Given this list of marker genes Gnas, Grm7, Calm3, Rgs2, Gnai1, Guca1b, Nherf4, Gnaz, Guca2b, Ncs1 (NCBI Gene Id 99076), Adgrv1, Calm1, Guca1a, Raf1, Guca2a, Calm2, here is a description of the gene set: Binds to and modulates the activity of an enzyme that catalyzes a ring closure reaction. studied in species Mus musculus Mouse Gene Set: GOMF_CYCLASE_REGULATOR_ACTIVITY